Given this list of marker genes JPH2, JPH3, RYR2, RYR1, CASQ2, JPH1, TRDN, AKAP6, ASPH, JPH4, here is a description of the gene set: species: Homo sapiens The part of the sarcoplasmic reticulum membrane that contains calcium release channels, is devoted to calcium release and is juxtaposed to transverse tubule membrane. The junctional sarcoplasmic reticulum membrane consists of the junctional region of the terminal cisterna membrane. Human Gene Set: GOCC_JUNCTIONAL_SARCOPLASMIC_RETICULUM_MEMBRANE